The following is a description of a gene set: studied in species Homo sapiens Any process that decreases the rate, frequency, or extent of the series of events that restore integrity to a damaged tissue, following an injury. Human Gene Set: GOBP_NEGATIVE_REGULATION_OF_WOUND_HEALING, and this is the list of marker genes: CEACAM1, NOS3, PRKCD, C1QTNF1, EDN1 (endothelin 1), TMX1, CD109, KLKB1, F2, CD9, FGB, FAP, PHLDB2, PDGFB, THBD, PTEN, TAFA5, TNF, VTN, EPPK1, TSPAN8, ALOX12, USF1 (upstream transcription factor 1), PRKG1, FIGNL2, MIR15B, WNT4, SMAD3, HRG, PF4, PLG, PROC, PLAU, MIR200B, SERPINF2, SERPINE2, SH2B3, FGG, MIR1298, UBASH3B, WFDC1, PDGFRA, KRT1, AJAP1, MMRN1, MIR34A, SERPING1, FGF2, CASK, PLAUR, SERPINB2, CLASP2, APOH, GP1BA, CPB2, PLAT, F12, CRK, PDGFA, KNG1, PROS1, CLASP1, ALOX5, F11, APOE, ADAMTS18, FGA, ANXA2 (annexin A2), THBS1, SLC12A2, TFPI, SERPINE1, APCS, MYOZ1, ADTRP